The following is a description of a gene set: This event has been computationally inferred from an event that has been demonstrated in another species.<p>The inference is based on the homology mapping from PANTHER. Briefly, reactions for which all involved PhysicalEntities (in input, output and catalyst) have a mapped orthologue/paralogue (for complexes at least 75% of components must have a mapping) are inferred to the other species. part of: M Phase Reactome Pathway: Mitotic Prometaphase species: Mus musculus electronically inferred by orthology from the curated human pathway, and this is the list of marker genes: Dynll1, Mis12, Clasp1, Cenpt, Tuba4a, Cenpj, Tubb2b, Cenpq, Actr1a, Cep192, Mad1l1, Ska1, Tubb6, Ndel1, Kif2c, Dctn1, Cep72, Nup85, Eml4, Tuba3b, Prkaca, Ndc80, Ninl, Tuba1a, Csnk2b, Mzt1, Nup133, Haus1, Cep63, Tuba1b, Cenpn, Cep57, Nudc, Cenpm, Tubb4b, Ywhae, Cenps, Hdac8, Tubgcp2, Ncaph, Cdk1, Cep131, Cep290, Itgb3bp, Smc3, Tubb4a, Nde1, Cep135, Firrm, Ppp2r5a, Nedd1, Tubgcp3, Kntc1 (NCBI Gene Id 208628), Haus8, Cep152, Tuba1c, Ppp2r5d, Sfi1, Seh1l, Ccnb1, Kif2b, Ppp2r5b, Sdccag8, Cep43, Dync1li2, Tuba8, Plk1, Tubgcp6, Cenpu, Haus5, Spc24, Csnk1e, Tubal3, Cenpe, Ppp2r1b, B9d2, Mad2l1, Prkar2b, Aurkb, Haus7, Cenpa, Cep41, Rad21, Xpo1, Zwilch, Stag1